The following is a description of a gene set: FRS-mediated FGFR3 signaling studied in species Mus musculus Mouse Gene Set: REACTOME_FRS_MEDIATED_FGFR3_SIGNALING, and this is the list of marker genes: Fgf9, Frs3, Fgf2, Fgf4, Sos1, Fgf20, Fgf8, Frs2, Fgf17, Fgf18, Kras, Fgfr3, Fgf16, Fgf23, Fgf1, Grb2, Fgf5, Hras, Ptpn11